Given this list of marker genes SLC25A51, RBP4 (NCBI Gene Id 5950), SPHKAP, PNOC, B3GALNT1, IFNA5, GABRB2, SFTPA1, GPR157, SLC25A39, GPBAR1, IL1A, B4GALNT4, TPO, KAZALD1, IL20, MIR369, RNF17, PPP1R37, FERMT1, CACNG2, KLRG1, DPY19L2, SSX9P, CCNK, MTHFR, MYOM2, SH3BP1, ICAM5, IGFBP6, FNTB, RPS23, TCF7, SUSD4, SLC19A2, USP26 (NCBI Gene Id 83844), PGBD5, VASH2, SLC26A4 (solute carrier family 26 member 4), LRP1, KLHL14, FOLR1, MIR129-1, TMEM254-AS1, GALNT15, ADGRB3, TMEM9B, APLN, SSBP1, NTHL1, TGFB1I1, SYCN, NRSN1, CHIA, GPC5, CAPN15, PCDHB5, P2RX6, LENG9, CAPZA3 (capping actin protein of muscle Z-line subunit alpha 3), PLCH2, AASS, MGST3, SH3PXD2B, GRTP1, GABRG3, KIFC3, PRELID3A, ODAD1, MGAM, IGF2-AS, PRR12, MIR670, F2RL3, GPRIN2, IQGAP3, UCN, ADAM7, TEX14, IL19, PDGFC, KRTAP5-4, LTC4S, UBD, SOX10, E2F4, ENOX1, TMEM179, LFNG, KRT77, SLC13A5, PPFIA2, PNLIPRP2, KRTAP19-7, RBM8A, SCN2A, GLP1R, RIBC2, LRRC4C, SELE, PTPN13, MEIS3, ADORA3, FOXI2, IRX3, FMOD, HAO2, ZNF112, C8A, MYO7B, IFITM1, SPINDOC, PACRG, MIR200A, GDF15, PALD1, ESM1, KRTAP4-1, OTX1, EGF, KCNQ3, LHFPL4, here is a description of the gene set: IL-10 or IL-6 stimulation of control 129xC57BL/6 murine bone marrow derived macrophages in the presence of LPS. We used microarrays to detail the global programme of gene expression changes in response to IL-6 or IL-10 stimulation in the presence of lipopolysaccharide. BMDMs were isolated from control, IL-6-/-, and IL-10-/- mice on a 129XBL/6 mixed background mice and differentiated in the presence of CSF-1 for 6-7 days. Cells were scraped and plated in 6 well plates at 2x10e6/well. Cells were washed with complete DMEM and rested for 1-2 hr before stimulation with combinations of IL-10 (10 ng/ml), IL-6 (2 ng/ml) or LPS (100 ng/ml) for 45 min or 180 mins. Complete biological replicates were performed. Human Gene Set: GSE5589_WT_VS_IL10_KO_LPS_AND_IL10_STIM_MACROPHAGE_180MIN_DN Genes down-regulated in bone marrow-derived macrophages at 180 min of stimulation with IL10 and LPS: wildtype versus IL10 knockout. from publication El Kasmi KC, Holst J, Coffre M, Mielke L, de Pauw A, Lhocine N, Smith AM, Rutschman R, Kaushal D, Shen Y, Suda T, Donnelly RP, Myers MG Jr, Alexander W, Vignali DA, Watowich SS, Ernst M, Hilton DJ, Murray PJ (PMID 17114459) species: Homo sapiens